Given this list of marker genes UBQLN4, MRE11, ERCC6, AUNIP, OGG1, SMCHD1, RADX, KAT5, SHLD1, TERF2, OTUB1, KMT5A, TFIP11, C1QBP, TWIST1, KLHL15, FANCB, SENP3 (SUMO specific peptidase 3), ABL1, SHLD3, MAD2L2, HSF1, RPS3, TP53BP1, RIF1, HELB, POLQ, MAGEF1, FBH1, RECQL5, RNF169, PLK1, CYREN, NUDT16L1, SHLD2, CSNK2A1, HMGA2, RMI2, MIR221, CGAS, PARPBP, here is a description of the gene set: Any process that stops, prevents, or reduces the frequency, rate or extent of DNA repair. Human Gene Set: GOBP_NEGATIVE_REGULATION_OF_DNA_REPAIR studied in species Homo sapiens